The following is a description of a gene set: Any process that modulates the establishment or extent of a membrane potential, the electric potential existing across any membrane arising from charges in the membrane itself and from the charges present in the media on either side of the membrane. species: Homo sapiens Human Gene Set: GOBP_REGULATION_OF_MEMBRANE_POTENTIAL, and this is the list of marker genes: ADRB1, GRIK2, KCNJ9, KCNH1, GCLM, FGF12, KCNA6, ABCC8, CHRND, SCN3A, KCNJ10, SCN7A, MTNR1B, KCNIP2, CHCHD10, NPR2, SLC29A1, KCNS2, PSEN1, CTNNA3, SOD2, SCN11A, ATP2A2, CHRNA7, CACNB4, ASIC1, KCNH3, NTSR1, KCNK4, SRC, CHRNA6, ATP1B1, TBX5, P2RX4, KCNA2, MYOC (NCBI Gene Id 4653), BEST2, SMAD7, DMD, RGS7BP, NOS1, MAPT, CRTC1, GNA14, KCNK13, SLC1A7, GPR88, KCND1, FZD9 (NCBI Gene Id 8326), GABRR2, GRIN2A, GCLC, FLNA, SLC4A11, CACNA1I, AGT, SUMO1, ATXN1, KCNN2, BAX, CALM1, GRID2, NTRK3, MIR181B1, KCNS3, WNT7A, KCNK6, P2RX1, SLC26A5, INSYN2A, KCNK5, DVL1, MIR1-1, MTCH2, CASR, GRIN3B, CALM3, RACK1, CHRM1, MPP2, GLRA1 (glycine receptor alpha 1), KCNA4, CACNA1C, SLC25A27 (NCBI Gene Id 9481), FMR1, KCNH2, TAC1 (tachykinin precursor 1), GRIA2, VCP, BIN1, CLCN1, MAPK8IP2, FKBP1B, ATP1A3, GRIN2B, KCNE5, MIR208A, KCNC4, SPART, GRIA3 (glutamate ionotropic receptor AMPA type subunit 3), CDKN2A, RTL10, KCNA1, BAD, AKT1, GBA1, PIEZO2, RNF207, GRIN2C, SCN9A, GABRA6, PPIF, CACNA1D, GRIN2D, HCN4, CHRNB4, CUX2, GJC1, NPPA, CACNA1G (calcium voltage-gated channel subunit alpha1 G), KCNH7, ATP1A4, ATP1B2, NETO1, PRKAR1B, CFTR, SCN4B, GABRA4, GABRD, CHRNB2, KCNJ11, ATP1A2, HTR3B, RIMS1, NRCAM, TBX18, MFN1, STX1B, NLGN1, CHRNB1, SCN1A, SLC24A4, SLC8A1, KCNMB2, POPDC2, MEF2C, NLGN2, OPRD1, MIR328, KCNA7, GRIK1, ACTN2, KCNG2, LTF, SLC34A1, YWHAH, NALCN, CAV3, RELN, RIMS4, SLC4A8, CHRNA2, GLRX, AKAP6, MET, PIP5KL1, BOK, PRKN, HTR3D, CHRNA5 (NCBI Gene Id 1138), PARP1, CACNB2, SLC26A3, P2RX6, SLC25A33, PID1, KCTD7, DRD1, WWP2, GABRB3 (gamma-aminobutyric acid type A receptor subunit beta3), KCNMA1, PPA2, INSYN1, ABL1, KCNJ3, KCNF1, KCNC2, TREM2, MTLN, CAMK2D, PIEZO1, SCN2A, MLLT11, PLN, KCNE4, CLN3, KCNN4, NLGN4X, DSP, GRIA1, DRD2, KCND2, SLC4A4, KMT2A, GABRG3, CD36, TRPM4, HCN1, KCNK16, APP, CCN6, GRID1, TSPAN9, DRD4, GPD1L, CBLN1, HSH2D, NEDD4L, CELF4, KCNJ8, CACNB3, YWHAE, TACR1, RNF122, EDN1, MYH14 (NCBI Gene Id 79784), P2RX7, TRDN, KCNC1, P2RX2 (purinergic receptor P2X 2), BCL2, P2RX5, PRKCZ, SSH1, CNR2, KDR, KCNQ2, TMEM25, TNF, ARRB2, NTRK2, GRIK3, TAFA4, SLC39A8, GLRA3, BEGAIN, ASIC3, CLIC1, KCNMB3, MIR29B1, TRPC5, CREB1, CXADR, ADRB2, NDUFC2, CLCN2, TBC1D24, CNGB1, ATP1A1, SCN2B, FHL1, GABRA1, CDK5 (cyclin dependent kinase 5), HCN2, BCL2L1, EIF4A3, CNIH3, PPP2R3C, ZMYND8, NLGN3, GABRB1, TUSC2, GLRB, CNTNAP1, PKP2, CACNA2D1, TSPO, NUP155, ABCC9, CHRFAM7A, ABCD1, SLC4A3, BAK1, PPP3CA, GABRR1, SLMAP, MIR30D, GPRIN3, KCNMB4, PTEN, KCNA10, ATP5IF1, HTR3C, ZMPSTE24, S1PR2, AKAP9, JUP, CACNA1H, GABBR1, KCNG4, NEDD4, KCNK9, COL6A1, NTSR2, SLC8A2, DSG2, ASIC5, SLC1A6, GRM1, CASQ2, MIR133A1, GHRL, RANGRF, HCN3, KCNB1, UCP2, GOT1, KCNJ2, CLDN19, CHRNA10, BNIP3L, BNIP3, FGF13, B2M, KCNE3, MIR30B, DSC2, KCNQ5 (potassium voltage-gated channel subfamily Q member 5), KCNH5, SLC9A1, CAV1, KCNK2, NPY2R, STOX1, SEZ6, NDP, UCN3, GNA11, PTPN3, GJA5, RGS7, ABAT, GLRA2, NPAS4 (neuronal PAS domain protein 4), KCNS1, TRPA1, NDUFS6, SCN3B, GSK3B, GRIK4, DLG4, UBB, PRELID1, AKAP7, PMAIP1, BID, WDR1, MIR26A1, KCNA3, MUL1, RYR2, KCNB2, GPER1, ADCY10, TRPV1, ANK2, BVES, DLD, GABRA2, NOS1AP, GRIN3A, SLC6A4, USP53 (ubiquitin specific peptidase 53), CHRNB3, GABRA3, KCNV2, HTR3E, KCTD16, GRIN1, DCN, SOD1, PHOX2B, GJD2, GABRA5, CHRNA3, UNC13B, GRM5 (glutamate metabotropic receptor 5), EHD3 (EH domain containing 3), SLC8B1, KCNQ1 (NCBI Gene Id 3784), RIMS3, ALB, DLG1, NRXN1, TMEM161B, SCN4A, GSK3A, FXYD1, P2RX3, KCNK1, ADORA2A, KCNE2, SHANK1, NNT, RIMS2, CHRNA9, KCNG1, CACNG2, CHRNA4, LRRK2, GRIK5, GRIA4, KCNQ3, ADRA1A, SNCA, KCNE1, GJA1, PINK1, NPFF, PRDX3, KCNA5, KCNJ5, KCNV1 (potassium voltage-gated channel modifier subfamily V member 1), KCNH4 (NCBI Gene Id 23415), CHRNA1, HTR3A, MTMR2, POPDC3, SCN10A, SHANK3, NPS, SLC25A36, KCNIP1, TMEM108, ASIC2, MECP2, STX1A, DMPK, SCN8A, KCNK3, PANK2, BBS10, PYCR1, RGS4, LIPA (lipase A, lysosomal acid type), KCND3, SCN5A, GABRG2, BAIAP2, SLC17A7, KCNH8, KCNH6, ARL6IP5, CHRNE, RAB3GAP1, KCNC3, SMAD3, ADORA1, KIF5B, KCNG3, MTOR, SNTA1, CHRNG, HCRT, BCO2, PTK2B (NCBI Gene Id 5748), PARK7, SCN1B, GABRB2, IFI6, ATP1B3 (NCBI Gene Id 483), ABCB5, ANK3, SLC8A3